The following is a description of a gene set: An abnormal pattern in the quality, quantity, or characteristics of sleep. studied in species Homo sapiens Sleep abnormality Human Gene Set: HP_SLEEP_ABNORMALITY, and this is the list of marker genes: ATXN8OS, AHDC1, NDP, SMC1A, TBC1D24, GPHN, PIGQ, CTBP1, MAGEL2, RAC1, FARS2, VAPB, NDN, TDP2, OCA2, ATP8B1, H4C5, PON1, RFX7, TBP, FBXO7, CRH, VAMP1 (vesicle associated membrane protein 1), CASK, TREM2, TPM3, PROKR2, USP7, C2CD3, HMGCL, IRF4, ASH1L, LIMK1, PER2, TRIO, FXR1, STIL, TCF4, GTF2I, AGO1, SYNGAP1, CNBP, PPT1, NR1H4, TSHR, HACD1, TCF20, TRAF3, TNFSF15, PABPN1, CTSK, GABBR1, MATR3, MECP2, TUBA1A, DAO, FKBP6, CHAMP1, CIC, CTSH, HUWE1, TSPYL1, FGFR3, CPLX1, DEAF1, TTC5, LRRK2, CHCHD10, MYL2, HMBS, VPS13C, HEPHL1, TFAP2B, UNC93B1, NSD2, ZMYM3, RERE, FTL, GJB1, ATAD3A, SYT1, WDR45, AIP, FUS, ABCB4, IMPDH2, NACC1, GLE1, SKI, MUSK (NCBI Gene Id 4593), FOXE1, CSNK2A1, EIF4G1, COL13A1, GNPTAB, AGRN, NIPBL, CHRNB2, KDM6B, EXT2, GRHL3, LARGE1, TGFBR1, FLII, JAK2, PUF60, MED27, ZBTB7A, ACTA1, LRRC32, PON3, ZFX, CCDC47, POGZ, VPS37D, CORIN, ASNS, CISD2, CPOX, HEXB, ARCN1, NGLY1, PTCH1, TRIM8, MTRR, BAP1 (NCBI Gene Id 8314), ATN1, SMARCE1, GCH1, ATXN7, BICD2, TBL2, GAS1 (NCBI Gene Id 2619), MKRN3 (makorin ring finger protein 3), HNRNPA1, SCN2A, SPIB, DNAJC13, GALNT2, ALG13, ZMYM2, PHIP, TRANK1, STX1A, MYOD1, DDB1, LIG4, CTNNB1, ERBB4, PRKAR1B, LAMB2, NODAL, SMC3, NF1, COA8, EML1, LARP7, NKX2-5, SELENON, PTS, TGIF1, KIF15, LIAS, TAF6, RET, DOK7, TRPV4, HDAC4, RECQL4, ADNP, DNMT1, FBXL3, MTFMT, CACNA1I, DISP1, SH3BP2, NSUN6, MYO9A, DPH5, SNAP25, GRIA1, FBXO28 (F-box protein 28, NCBI Gene Id 23219), ASXL1 (ASXL transcriptional regulator 1), CDK13, RFC1, RNH1, DKK1, TRAF7, PER3 (period circadian regulator 3), NFIX, GPR101, NUP88, SLC18A2, PTPA, PHOX2B, CHMP2B, BMP2 (bone morphogenetic protein 2), MLXIPL, ASCC3, UNC13A, UNC80, SLC25A22, SIX3, EIF4H, PINK1, FGF8, SRPX2, HDC, VPS35, SIN3A, OPTN, FRA10AC1, GUSB, CLIP2, CA2, NAA10, TANC2, CALR, COL3A1, MEN1, PFN1 (profilin 1), SLC2A3, TMEM270, ZIC2, EPG5, SLC25A13, GLT8D1, SLC5A7, ARL3, HLA-DQB1, TBC1D20, EIF3F, P2RY11, KAT5, NEFH, NDUFAF2, FBXO11, ERCC6, FIG4 (NCBI Gene Id 9896), CAMK2A (calcium/calmodulin dependent protein kinase II alpha), NR4A2, IL12A (interleukin 12A), HESX1, RNU7-1, SH2B3, SUCLG1, CACNA1C, ARSB, SMARCC2, GTF2IRD2, PRPH, MED23, AIFM1, UBE3C, CRELD1, FGFR2, TERT, TSEN34, ABCB11, MAPT, ALDH4A1, GBA1, DNAJC6, ELN, STOX1, HIBCH, SETBP1, MOG, TNFSF4, TNRC6B (NCBI Gene Id 23112), EBF3, IQSEC2, DDC, PAX8, ITGA7, BICRA, TSEN2, SGSH, SMARCB1, EP300, POU2AF1 (POU class 2 homeobox associating factor 1), ATXN2, TIMELESS, DPH2, SNORD115-1, UBQLN2, PRMT7, TUBB3, ATXN10, PWRN1, POU3F3, UBE3A, GLRB (glycine receptor beta), GNAO1, SPOP, RUNX2, SEPSECS, MPL, TNNT1, PDGFB, HERC2, SQSTM1, ATP7B, IDS, DUOX2, ADH1C, DEPDC5, VPS4A, SPTBN1, TNPO3, AFF4, VPS51, ANXA11, NONO, TPM2, POMT2, GABRG2, PI4K2A, PDE2A, HDAC8, ARNT2, SOD1, PRKN, SOX2, SPR, KCNA1, SATB2, RFC2, AKT1, IDUA, DMD, MAP3K20, TSEN15, SLC18A3, NOL3, TBK1, TAF1, APOE, NEUROD2, SPTSSA, CLCNKB, SOX9, GRIA3 (NCBI Gene Id 2892), RIC1, MRPS34, FGFR1, NEK1, LRPPRC, SUPT16H, MFSD8, PNKP, POMT1, CCNF, ATP10A, PODXL, SUFU, RAB11B, NF2, METTL27, PIGP, NEFL, EMC10, NELFA, IL12RB1, GLRA1, GABBR2, WDR73, LTBP3, GATAD2B, GABRB3, PIGG, RAPSN, IRF5, KMT2A, WAC, FKTN, GNAQ, CREBBP, GTF2IRD1, YY1, RAD21, GFAP (glial fibrillary acidic protein), CRY1, DBH, SNCAIP, SLITRK1, PIGT, CHRNA4, UCHL1, FOXH1 (NCBI Gene Id 8928), PARK7, TELO2, CABP4, PLCB4, KIF21A, GNS, ARX, CEP57, KMT5B, HGSNAT, CARS1, RPS6KA3, NOTCH3, SIK1, PHKA2, GNE, SLC25A1, SLC22A5, PRR12, TP53, PRPS1, ACAT1, ZNF365, WDR4 (NCBI Gene Id 55896), VPS13A, HNRNPC, SEPTIN9, SPART, IFNG, NCF1, FBP1, DHX30, ASCL1, FOXG1, RAI1, GIGYF2, ATXN3, COLQ, ZNF462, BUD23, FKRP, NCAPG2, PTRHD1, SNORD116-1, ASXL3, PYGL, PIK3CA, GRM7, CAMK2B, TWIST1, GNAI3, ANG, CAPRIN1, ACBD6, PSEN2, NPAP1, SIM1, KCNT1, MT-TT, STAG2, GRB10, CHKA, DPH1, MEFV, P4HTM, WBP4, SMO, PIDD1, SLC6A5, DPYS, TET2, DMXL2, EEF1A2, PCGF2, MFN2, TARDBP, TSC1, DLL1, SLC32A1, BRAF, FXN, NHLRC1, ASPA (NCBI Gene Id 443), NADK2, SLC12A3, MBD5, FMR1, FLCN, CNOT1, SHANK3, SCN1B, CHD8, ABCC9, BSCL2, ATAD1, RNU4-2, CHCHD2, VRK1, OTX2, DNA2, SYNJ1, NDUFS2, DNAJC30, MYT1L, CHRNA2, DHCR7, GSN, EHMT1, CRIPTO, DMPK, NALCN, ERCC8, CSNK1D, EDN1 (NCBI Gene Id 1906), ALMS1, NAGS, SETD1A, SOX3, PWAR1, COQ2, ADGRL1, VCP, PON2, AGA, SLC2A1, UBAP2L, ZBTB20, SPTAN1, NUP54, MED12L, PLCH1, NAA80, TLR3, UQCC3, HTT, FLT1, TFE3, ANK3, NSUN2, DVL1, ADRB1, ZEB2, MCM3AP, CDC42BPB, NTNG1, UBB, SARDH, KAT6A, SNRPN, HCRT, DCTN1, PHEX, CHAT, EXOC2, CTCF, BAZ1B, DYRK1A, KIF11, SLC9A6, CACNA2D1, GLI2, NSDHL, TTI2, TWNK, SLC26A4, HLA-DRB1, TAF15, SYT2, SNCA, HRAS, AP3B2, POLR2A, PHKG2, STUB1, TICAM1, LETM1 (leucine zipper and EF-hand containing transmembrane protein 1), NAGLU, SLC35C1, MMEL1, GRIN1, ADRA2A, NKX2-1, SATB1, PPARGC1A, CDKL5, HTRA2, NEUROG1, TSC2, RTTN, SETD5, PRNP, ERCC4, GRIN2A, ATP9A, WFS1, NDST1, CFAP410, CDON, EPM2A, ATP1A2, BCL11A, TSEN54, BRD4, SHH (sonic hedgehog signaling molecule)